Given this list of marker genes UBR4, PIK3IP1, SELL, KRT15, SLC39A10, ENSG00000284691, AGO2 (argonaute RISC catalytic component 2), ABLIM1, USP7 (NCBI Gene Id 7874), F5, NFAT5, PRXL2A, IKZF2, ALS2CL, ZBTB20, ATM, LGMN, PHGDH, PCDHB3, ZKSCAN7, TMT1A, MTURN, CRIP3, WWP1, FRMPD1, DENND5A, APBA2, NSD3, APPL2, ATXN7L1, AK5, ATP1A1, ZDHHC21, RAB43, MAML2, CAMK4, ASH1L, PHIP, GLCCI1, ANKRD55, TMEM196, RNF122, PIWIL1, USP34, LINC01089, CRTC3, CBS (NCBI Gene Id 875), CALM3, KLHL3, TIGIT, VRK3, IPCEF1, KLF7, MAP4K4, PKM, CCDC110, FAAP24, NCAPD2, MEIS3P1, SAE1, BPTF, MYCBP2, SLC18B1, VNN2, USF3, AFF4, IL4R, TCF7, LRRC37A2, FAM13A, ZNF451, FAM236A, CEP68 (NCBI Gene Id 23177), HERC1, SPTBN1, TTN, SMG1, SERTAD2, GRIK5 (glutamate ionotropic receptor kainate type subunit 5, NCBI Gene Id 2901), TXK, TAOK1, DBH-AS1, LRRC8D, CD7, SNHG7 (small nucleolar RNA host gene 7), PKMYT1, IL21R, KLHDC3, HDAC8, ZNF479, TMEM272, EP400, MTUS1 (microtubule associated scaffold protein 1), TSHZ2, HTR6, ABCC1, TENM1, NOG, IL12B (NCBI Gene Id 7907), FAM117B, TLR5, TRIB2, IQCC, CHST2, PCED1B, CERS6, PGAP1, CD68, PDE7B, MEOX1, MARCKSL1, ASGR2, KMT2A, AEBP1, RASA2, AGMAT, ABCC2, PLAC8, TUG1, OTULINL, SFI1, CTSL, DTX1, FOXP1, C16orf87 (chromosome 16 open reading frame 87), MAP3K1 (NCBI Gene Id 4214), PPP3CC (NCBI Gene Id 5533), CDH1, AMN1 (antagonist of mitotic exit network 1 homolog, NCBI Gene Id 196394), CCNE1, CNKSR2, TCEA3, MYCBPAP, SELP, IRF4, KAT6A (NCBI Gene Id 7994), MYB, GPR155, PELI1, KRT1, GPA33, SDCBP2-AS1, TRRAP, ICOS, CNST, IL6ST, HIVEP1, GOLGA7B, CD27, ACTN1, RNF138, TMEM131L, KALRN, FOXP3, TET3, EDAR, IGSF9B, SAMD4B (sterile alpha motif domain containing 4B), PTPRS, PDE3B, KLF3, TBL1X, SESN3, TNIK (NCBI Gene Id 23043), SNN, MERTK, PTK2 (protein tyrosine kinase 2), PDK1, MLLT3, CACNA1I, ASAP1, LEF1-AS1, SLC8B1, RIF1, CHKA, BEX3, CTSLP8 (cathepsin L pseudogene 8), BCL2A1, SSH2, LGALS13 (galectin 13), MACF1, LDLRAD4, LEF1, SCML1, GAL3ST4, ACOD1 (NCBI Gene Id 730803), MDN1, LINC01550, TSPAN14, here is a description of the gene set: Microarray deconvolution is a technique for quantifying the relative abundance of constituent cells in a mixture based on that mixture's microarray signature and the signatures of the purified constituents. It has been applied to yeast and other systems but not to blood samples. Here we test the ability of this technique to determine the fractions of subsets of memory T cells in peripheral blood mononuclear cell (PBMC) samples. from publication Abbas AR, Wolslegel K, Seshasayee D, Modrusan Z, Clark HF (PMID 19568420) Human Gene Set: GSE11057_EFF_MEM_VS_CENT_MEM_CD4_TCELL_DN studied in species Homo sapiens Genes down-regulated in comparison of effector memory T cells versus central memory T cells from peripheral blood mononuclear cells (PBMC).